The following is a description of a gene set: studied in species Homo sapiens We used microarrays to compare interferon-alpha (IFNa)- and interferon-gamma (IFNg)-stimulated genes under an equivalent biological input. The goal was to compare IFNa- and IFNg-stimulated genes, as well as to identify common and distinct sets of type I and II ISGs. from publication Liu SY, Sanchez DJ, Aliyari R, Lu S, Cheng G (PMID 22371602) Genes up-regulated in bone marrow-derived macrophages: interferon alpha versus IFNG. Human Gene Set: GSE35825_IFNA_VS_IFNG_STIM_MACROPHAGE_UP, and this is the list of marker genes: ADHFE1, DTX2, SH3TC1, ERRFI1, SOCS1, SPI1, MAFG, PVR, FBXO2 (F-box protein 2), EIF1, EIF4EBP1, GBP4, NT5C3A, DDX60, CD69, GSAP, GPD2 (glycerol-3-phosphate dehydrogenase 2), SUPT6H, ATXN7L1, KDM7A, TNIP2, CGREF1, ARMCX4, NLRP3, JUNB, POLR3D, IRF7, TREX1, MET, STAT1, BRD2, TENT4A, APTX, CCRL2, PTPRE, RNF149 (ring finger protein 149), IL27, RIGI, KTN1, CALCRL, ADAMTS7 (ADAM metallopeptidase with thrombospondin type 1 motif 7), OSBPL3, FLRT3, IFNAR2, OAS2, TRIM5, CMPK2, ZYX, VTA1, BATF, TAP1, RAB3IP, SERTAD2, SLFN5, ARMCX1, GBP3, CFLAR, EDN1, GBP2, CXCL9, PRPF38A, RAB38, ACVR1B (NCBI Gene Id 93351), RTP4, HEATR6, CFB, IL1RN, PFKL, DAAM1, POLR2D, MTF2, RAB20, PARP12, TES, SLCO3A1, KPNA3, CRHR1 (corticotropin releasing hormone receptor 1), GBP5, EHD1, SLC25A17, REPS1, TPBG, ETS1, UBE2Q2, ZC3H12A, ZCCHC2, CWC15, SLC2A1, SNX10, SERTAD1, IER3, RFFL, ATF3, PPARGC1A, PPP1CB, COQ10B (NCBI Gene Id 80219), KPNA4, TTC39C, SLC6A15, HIF1A, KLF7, SAMSN1, ELMO3, LIMD1, FNBP1L, HIVEP2, TMEM123, ACOT9, DUSP16, MYADM, DENR (density regulated re-initiation and release factor), HCK, HCAR2, NFKB1, SAP30, LYPD6B, RASGRP1, CERS6, RSAD2, PARP14, OTUD7A, CXCL3 (C-X-C motif chemokine ligand 3), SLC7A2, MX1, IFI16, ZFP36, ANP32A, DUSP1, SH2B2, STK40, STAT2, ZBP1, GPR35, VCAM1, ZC3H12C, ATP6V1E1, MDM2, ZFAND5, LRRK2, PRELID2, TOR1AIP2, MOB3B, MMP13, IFIT1, IFIT2, BNIP3, IRGM, NHERF1, RAP1B, CXCL2, GBP6, CD40, PELI1, ATOH1, CCNJ, GINM1, ACSL1, SRFBP1, GCH1, NFKBIB, HERC5, CXCL10, MBD1